The following is a description of a gene set: species: Homo sapiens from publication Chen Y, Wang X (PMID 31504780) Genes predicted to be targets of miRBase v22 microRNA hsa-miR-6502-5p in miRDB v6.0 with MirTarget v4 prediction scores > 80 (high confidence targets). Human Gene Set: MIR6502_5P, and this is the list of marker genes: ARIH1, MYLK3, FAM98A, RNF166, N4BP2L1, VWA2, B3GNT2, ERI1, ADD3, WNT2, NUDT7, MACIR, ZBTB34, XRN1, RABEP1, TEP1, ISLR, SNX18, HTR5A, MIER3, RNF10, NCSTN, HOXB13, TRABD2B, MAN1A2 (NCBI Gene Id 10905), ANKRD42 (NCBI Gene Id 732033), CPEB2, EIF4E2, TRIM8, SCD5, LHCGR, TSPAN7, LRAT, URI1, CAMSAP2, NCK1, KCNMB2, THSD7A, INSM2, OOSP2, HMGN3, ZFHX2, RGS8, SLC35A1, WNK1, SLC6A1, SNAP25, TMEM33, GPD2, ADAM12, ZRANB1, TAOK2, MAP2